The following is a description of a gene set: Genes negatively differentially expressed in cell type: B cell upon treatment with cytokine: AdipoQ in mouse lymph nodes in vivo. Mouse Gene Set: CUI_B_CELL_ADIPONECTIN_RESPONSE_DN Cytokines mediate cell-cell communication in the immune system and represent important therapeutic targets. A myriad of studies have highlighted their central role in immune function, yet we lack a global view of the cellular responses of each immune cell type to each cytokine. To address this gap, the authors created the Immune Dictionary, a compendium of single-cell transcriptomic profiles of more than 17 immune cell types in response to each of 86 cytokines (>1,400 cytokine-cell type combinations) in mouse lymph nodes in vivo. A cytokine-centric view of the dictionary revealed that most cytokines induce highly cell-type-specific responses. For example, the inflammatory cytokine interleukin-1β induces distinct gene programmes in almost every cell type. A cell-type-centric view of the dictionary identified more than 66 cytokine-driven cellular polarization states across immune cell types, including previously uncharacterized states such as an interleukin-18-induced polyfunctional natural killer cell state. from publication Cui A, Huang T, Li S, Ma A, Pérez JL, Sander C, Keskin DB, Wu CJ, Fraenkel E, Hacohen N (PMID 38057668) species: Mus musculus, and this is the list of marker genes: Vpreb3, Fos, Zfp36, H1f2, Ddx5, Fcer2a, Klf2